The following is a description of a gene set: Mouse Gene Set: GOCC_ISWI_TYPE_COMPLEX species: Mus musculus Any nuclear protein complex that contains an ATPase subunit of the imitation switch (ISWI) family. ISWI ATPases are involved in assembling chromatin and in sliding and spacing nucleosomes to regulate transcription of nuclear RNA polymerases I, II, and III and also DNA replication, recombination and repair., and this is the list of marker genes: Chrac1, Smarca5, Hmgxb4, Rsf1, Smarca1 (NCBI Gene Id 93761), Pole3, Luzp1, Baz2a, Baz1a, Baz1b (NCBI Gene Id 97273), Rbbp7, 0610010K14Rik, Cecr2, Bptf, Rbbp4